The following is a description of a gene set: Human Gene Set: GOMF_PEPTIDASE_ACTIVATOR_ACTIVITY Binds to and increases the activity of a peptidase. species: Homo sapiens, and this is the list of marker genes: WDR48, TANK, PSME3, PRSS22 (NCBI Gene Id 64063), FURIN, ST20, RACK1, CASP1, ADRM1, CARD8, NOD1, LGMN, DMWD, APP, PSMD14, NGF, MAL (NCBI Gene Id 4118), NLRP1, HSPD1, PCOLCE, EBAG9, PSME1, BCL2L13, SFRP2, TIMM50, APAF1, PCOLCE2, NCSTN, PSME4, PSENEN, CTSC, BEX3, CASP8AP2, TIFAB, SVBP, AIM2, TGFB1, MAPK12, MALT1, APH1B, NDUFA13, NLRP12, NRDC, PINK1, ATP2A3, CLPX, FN1, NKX3-1, CAV1, BAD, CTSH, NLRC4, VCP, PYCARD, APH1A, PSME2, FBLN1, ROCK2, VSIR, WDR20, NLRP3